Given this list of marker genes Usf2 (upstream transcription factor 2), Mpnd, Rpl6, Psmd4, Arf5, Psmb9, Itm2b, Fkbp3, Bloc1s4 (biogenesis of lysosomal organelles complex-1, subunit 4, cappuccino), Cldn5, Nfix, Cd9, Lamtor3, Anapc11, Dtnbp1, Cyb5r3, Atp5mc2, Cmip, Lsm2, Psmc4, Kdelr1, Lrpap1, BC064078, Ninj1, Ypel3, Tmem238, Nabp2, Thap3, Nfkbiz, Ubb, Pnrc1, Uchl5, Ccs, Gabarapl1, Adora2b, Rpsa, Pa2g4, Ino80e, Bbc3, Bcl7c, Denr, Ormdl3, Spsb2, Smarce1, Cfl1, Mgst1, Lgals3, Bag1, Rbm26, Plcb3 (phospholipase C, beta 3), Ncln, Acta2, Sparc, Ptms, Tmem176b, Dnase1l3, Csnk2b, Rpl13a, Eif4g1, Samm50, Bcl9l, Wdr89, U2af1 (U2 small nuclear ribonucleoprotein auxiliary factor (U2AF) 1), Srsf5, Phlda3 (pleckstrin homology like domain, family A, member 3), Emd, Cbx2, Gadd45gip1, Ier3, Prr13, Oaz2, Fosl2, Bsg, Casz1, Lias, Mtch1, Ethe1, Fam3a, Ilkap, Klf13, Pold4, Spry1, Ltbp4 (NCBI Gene Id 69644), Tbcb, Efs, Mcrip1, Ddrgk1, B2m, Tpm3, Pmf1, Lmo4, Rps3a1, Rps15a-ps6, Zfp703, Polr2c, Faim, Cdc37, Tbc1d31, 0610010K14Rik (RIKEN cDNA 0610010K14 gene), Fermt3, Erp29, Gjb6, Cebpg, Cirbp, Ubb-ps, Stx4a, Plac8, Lamtor4, Scp2, Exosc5, Rbm25 (NCBI Gene Id 70221), Sdc4, H2-Eb1, Stub1, Nfkbil1, Lrp4, Triap1, Rapgefl1, Hmgn1, Timm44, Cbarp, Rassf4, Sfr1, Cxcl10, Sdhc, Dhrs3, Zfp710, Crip2, Gata3, Znhit1, Ube2e2, Ing1, Cltb, Bok, Lrrc8a (leucine rich repeat containing 8A VRAC subunit A), Shisa5, Sf3b2, Iffo2, Vasp, Rack1, Map2k2, Ptprc, Tmem234, Nsmce3, Cd74, Ifitm2, Ing2, Tmem11, Cobl, Rab11b, Arl4a, Wbp1, Csrp1, Rfxap, Nans, Acer1, Lypd8, Fstl3, Etfb, Spr, Tmem50a, Cd63, Dusp7, Kcnk7, Echs1, Pou3f1, Ccl6, Fam32a, Guk1, Reep5, Swi5, Npc2, Atg9a, Casc3, Klf5, Tmem106c, Drap1, C1qtnf12, Zfp442, Abhd16a, Ywhae, Arhgdia, Ppp1r11, Myo1c, Exosc7, Gfus, Ctcf, Smco4, Tmem160 (NCBI Gene Id 69094), Macrod1, Aldh2, Trappc3, Tpt1, Mapk3, Chmp6, Ccl2, Fkbp8, Ppp1r35, Mob3b, Ssna1, Gas2l1, Tspan17, Rab5c, Prdx6, Gar1, Wbp2, Atp6v1d, Barx2, Aup1, Rp9, Ubl7, Psmb4, Dexi, Ddb1, Irx5, Med8, Ptma, 1810034E14Rik, Manbal, Spint2, Tsc22d1, Rabac1, Ftl1, Rpl31-ps12, Brd3, Eif5a, Cebpd, Egfl7, Fbl, Rabl6, Tomm6, Has1, Dnajc13, Cd53, Exosc6, Srsf9, Slpi, Eif3f, Ap1s1, Kxd1, Prrg2, Hdgf, Dlx5, Calm5, S100a14, Cdk5, Gga1, Pdlim2, Rxra, Pex14 (peroxisomal biogenesis factor 14), Smim14, Zfp511, Foxq1, Sod2, Mxra8, Cd37, Pip4p1, Metrnl, Orai1, Sdcbp2, Cdkn2b, Chmp2a, Fis1, Mal, Hebp2, 2310011J03Rik, Hnrnpul2, Epb41l4b, Rps5, Rassf7, Dedd, Ptpn1, S100a16, Ctdnep1 (CTD nuclear envelope phosphatase 1), Scamp4, Mllt10, Edn1, Capns2, H2-DMa, Polr3gl, Mgp, Dlgap4, Rgs1, Ybx1, Fam241b, Nfic, Arl6ip4, Mif4gd, Ccn1, Stmn1, Dcakd, Oaz1, Tex261, Nupr1, Vim, BC004004, Nudt18, Vcf1, Prdx5, Psmc3 (NCBI Gene Id 19182), Tsen34, Nectin2, Nsd3, Gatd3a, Tle5, Ptov1, Junb, Ccdc80, Tmem259, Cenpb, Bcl2l1, Aimp1, Ctnnbip1, Pfn1, Senp6, Crb3, Rps7, Anp32b, Nbl1, Tmem205 (transmembrane protein 205), Mdh1, Coq7, Tecr, Eif3k, Cox7a2l, Hpf1, Plscr3, Gas7, Hmg20b, H2-D1, Nfkbib, Mrpl24, Spin1, Gpha2, Kif1c, Psma6, Gpx4, Acot8, Tmed9, Phpt1, Arpc1b, Arl13b (ADP-ribosylation factor-like 13B), Nudt9, Ndrg2, Rps3, Echdc2 (enoyl Coenzyme A hydratase domain containing 2), Irf2bpl, Bex3, Tmem109, Lamtor1 (NCBI Gene Id 66508), Pim3, 2510002D24Rik, Rbfa, Smim5, Cxcl14, Rhob, Efna1, Gid4, Txn2, Tmem40, Jund, Cdkn2d, Spag7, Ube2v1, Fcer1g (NCBI Gene Id 98395), Bri3bp, Hras, Rpl3, Leng1, Slc6a8, Rhov, Clic1, H2ax, Lgals9, Dnajc9, Tyrobp (NCBI Gene Id 22177), Igfbp7, Tuba1b, Tssc4, Abhd14b, Plp1, Mrpl2, Cep170b, Med4, Bicdl2 (NCBI Gene Id 212733), Klf16, Wdtc1, Vps28, Hagh, Atp6v0b, Tmem79, Sap30l, Mydgf, Ccdc124, Nfkbia, Mbp, Ybx3, Ostc, Mapkbp1, Cdc123, Tra2a, Zfand2b, Clca2, Eeig1, Samd4b, Use1, Rps10 (ribosomal protein S10), Phb2, Ppig (NCBI Gene Id 228005), Abhd17a, Mmp24os1, Otulin, Rpl13, Akirin2, Ubald1, H2-Aa, Calm2, B3gat3, Gm9320, Rnf126, Aen, Tubb5, Pfdn6, Czib, Ssbp4, Ptprcap, Nt5c3b, Fosl1, 1110038F14Rik, Bcl7b, Pin1, Vamp2, Lypla2, Gnb1, Babam1, Cdkn1a, Usp19, Akt1s1, Ccdc85b, Ddr1, Fgfbp1, Fam89b, Ino80b, Unc93b1, Esrra, Nop53, Krt4, Ptpn23, Pfdn2, Ndufa4l2, Zfp36l1, Tacc2, Grhpr, Rac2, Vps72, Bccip, Cdk9, Lxn, Tnfrsf1a, 2410002F23Rik, Plgrkt, Notch3, Tnfaip6, Rplp0, Rpl5, Psmb8, Hyi, Hs3st6, Pkig, Naa10 (N(alpha)-acetyltransferase 10, NatA catalytic subunit), Kdm6b, Sfn, Bod1, Mvb12a, Nhsl3, Akr1a1, H2-K1, Smagp, Fez1, H1f0, Klf4, Mark2, Rps20, Hsd17b8, Mbd3, Bin1, Evpl (envoplakin), Igfbp4, Ube2m, Cic, Elof1, Ece1, Krt14, Zfp414, Creld2, Srgn, Phf23, Slc10a6, Mrps26, Krt17, Ergic3 (NCBI Gene Id 99284), Rnf7, Yif1a, Dhrs4, Pdrg1, Selenow, Dusp22, Adrm1, Dpep1, Szrd1, 2610528J11Rik, Ier2, Ubxn1, Mpst, Pebp1, Psme1, Eef1b2, Rrad, Atg101, Ly6g6e, Gnaq, Ltb, Zfp36, Gipc1, Sumo3, Mycbp2, Fos, Mrps12, Serbp1 (NCBI Gene Id 66870), Gpatch4, H2-Ab1, Acbd4, Cd82, Commd9, Krt5, Clic4, Rit1, Gnb2, Arpc3, Fance, Ctsz, Sf3b4, Mrto4, AW112010, Mospd3, Tmub1, Jagn1, Inka1, Krt13, Ap2s1, Grina, Wdr83, Sirt2, Cited2, Sertad1, Zfpl1, Klc3, Rpl4, Egr1, Elf3, Nr4a1, Tubb4b, Rab24, Notch1, Tmed3, Mmp2, Dcn, Htatip2, Gmfg, Col6a3, Ltb4r2, Dgcr6, Emc10, Ccdc115, Trappc6a, Tfpt, Rexo1, Anxa8, Mrps18a, Cebpa, Tmem119, Rock1, Igbp1, Snrpc, Evi2a, Map1lc3a, Utp3, Hyou1, Rex1bd, Ppp1r13l, Rarg, Csrnp1, Zfr, Nr4a2, Bad, Nudt3, Gng10, Rnf220, Lypd3 (NCBI Gene Id 72434), Mettl5, Itgb1bp1, Bri3, Nr2c2ap, Snrpa, here is a description of the gene set: Mouse Gene Set: TABULA_MURIS_SENIS_SKIN_EPIDERMAL_CELL_AGEING studied in species Mus musculus from publication Tabula Muris Consortium (PMID 32669714)